Given this list of marker genes TSPO, SLC39A9, AR, ALDH1A1, SHBG, here is a description of the gene set: species: Homo sapiens Human Gene Set: GOMF_ANDROGEN_BINDING Binding to an androgen, a male sex hormone.